The following is a description of a gene set: studied in species Mus musculus Mouse Gene Set: MIR_1928 from publication Chen Y, Wang X (PMID 31504780) Genes predicted to be targets of miRBase v22 microRNA mmu_miR_1928 in miRDB v6.0 with MirTarget v4 prediction scores > 80 (high confidence targets)., and this is the list of marker genes: Or7d10 (NCBI Gene Id 258336), Atp1b1, Gnb3, Bend4, Ythdf3, Tmem132c, Cmtm4, Lhfpl2, Cldn34c1, Ntf3, Paip1, Dlx1, Mapk6, 4930544G11Rik, Fbxo30, Itga3, Bmpr1a, Adam22, Bbc3, Arhgef7, Tle3, Brwd3, Fam221a, Eml6, Esr1, Creg2, Trp53bp2, Scai, Tmem167, Etv3, Agtr1a (angiotensin II receptor, type 1a), Trim36, Cldnd1, Phactr4, Dpp8, Tmprss11f, Itgb3, Rab1a, Rad51c, Pramel22, Zfp950, Eif3j1, Thoc1, Zfpm2, Fsbp, Hipk1, Rala, Vash1, Kmt5b, Mospd1, Wdr47, Golga1, Wdr37, Cbfb, Or52n4, Slfn8, Dennd1b, Dcun1d1, Pkdcc, Plekhb2, Ilf2, Ap3b2, Cnr1, Hectd2, Rbm24, Coa5, Ddit4 (DNA-damage-inducible transcript 4), Irx5, Arf4, Kit, Zfp426, Btg2, Psap, Nkiras1, Gnai2, Ptprz1, Zfp385a, Hmbox1, Atad2b, Fermt2, Nrk, Tshr, Galnt18, Atad2, Nfyb, Lrrtm2, Dcaf12, Dock9, Fos, Esco2, Crebzf (NCBI Gene Id 70721), Pramel27, Cdkn1b, Vmac, Bcl2l11, Mllt6 (NCBI Gene Id 246198), Zbtb4, Dmrt3, Acp3, Sbk1, Adipor1, Rfk, Gabra2, Mia3, Syn3, Eif3j2, Midn, Rbm11, Ppp2r2a, Cacnb4 (calcium channel, voltage-dependent, beta 4 subunit), 2510009E07Rik, Brwd1, Megf9, Ralgapa1, Nfat5, Gucy1a2, Plpp3, Hapstr1, Tmem165, Rfx6, Gas2, Nsmce4a, Mylip (myosin regulatory light chain interacting protein), Exo1, Cdca3, Rnps1, Erbb4, Cxcl12 (NCBI Gene Id 20315), Prrg3 (proline rich Gla (G-carboxyglutamic acid) 3 (transmembrane)), Agps, Trabd2b, Atxn1, Ankrd29, Rgs6, Smarca5, Angptl2, Mark1, Sun2, Slc15a5, Syne1, Dhx36, Atosa, Foxn2, Far1, Zfp869, Dcaf17, Tcf12, Fndc3a, Cobl, Casz1, Tmem236, Tet1 (NCBI Gene Id 70318), Braf, Ppp3r1, Tnrc6c, Clvs2, Gpr155, Clec1a, Pik3r1, Egfr, Fgf14, Tmcc1, Chd2, Fmr1, Plcl2, Gabra1, Dcun1d4, Mier3, Vapb, Gab1 (NCBI Gene Id 14388), Rfx7, Fat2, Stat1, Kif16b, Ube2j1, Rcbtb2, Pi15, Sema6d, Cdh2, Ptbp3 (polypyrimidine tract binding protein 3), Rev3l, St6galnac3, Fry, Fam120a, Gphb5, Adar, Cdk19, Chsy1, Msl2, Sybu (NCBI Gene Id 319763), Lims1, Upf3b, Sparcl1, Shprh, Plekha2 (pleckstrin homology domain-containing, family A (phosphoinositide binding specific) member 2), Ino80d